The following is a description of a gene set: Human Gene Set: GSE41978_WT_VS_ID2_KO_AND_BIM_KO_KLRG1_LOW_EFFECTOR_CD8_TCELL_UP studied in species Homo sapiens Genes up-regulated in KLRG1 low CD8 T effector cells during infection: wildtype versus ID2 and BCL2L11 knockout. CD8+ T cells play a crucial role in the clearance of intracellular pathogens through the generation of cytotoxic effector cells that eliminate infected cells and long-lived memory cells that provide enhanced protection against reinfection. We have previously shown that the inhibitor of E protein transcription factors, Id2, is necessary for accumulation of effector and memory CD8+ T cells during infection. Here we show that CD8+ T cells lacking Id2 did not generate a robust terminally-differentiated KLRG1hi effector population, but displayed a cell-surface phenotype and cytokine profile consistent with memory precursors, raising the question as to whether loss of Id2 impairs the differentiation and/or survival of effector-memory cells. We found that deletion of Bim rescued Id2-deficient CD8+ cell survival during infection. However, the dramatic reduction in KLRG1hi cells caused by loss of Id2 remained in the absence of Bim, such that Id2/Bim double-deficient cells form an exclusively KLRG1loCD127hi memory precursor population. Thus we describe a role for Id2 in both the survival and differentation of normal CD8+ effector and memory populations. from publication Knell J, Best JA, Lind NA, Yang E, D'Cruz LM, Goldrath AW (PMID 23325888), and this is the list of marker genes: TRIO, NHERF4, SLC14A1, FRYL, IRF1, ZSCAN5B, TUBGCP4, MFAP1, FCER1A, XIAP, HGSNAT, ZNF213, PDCD1, MBD4, GABARAPL1, SEPHS1, GINS4, EEF2K, C1orf159, UBE2C (NCBI Gene Id 11065), SRRD, H2AX, KIF18A, EME1, CXCR3, NT5C, EML5, CUL4B, BCAS3, TEX11, MFSD10, KLHL42, MATN3, CENPM, POPDC3, ACOT9, C19orf53, BIRC5, CREG1, TUSC2, PEX2, PHYH, DLGAP5, ITGA6, EFHD1, GDF5, FBH1, MOS, GMFB, ZNF418, SLC4A5 (NCBI Gene Id 57835), FUT7, RAPSN, FAM53C, CNR2, TRPC4, SYNJ2BP, DGCR6, GAS8, HAUS5, SNRK, CD2BP2, ARL2BP, METRN, IFIT2, LAGE3, SUMF1, TTLL1, NAB1, PAPOLG, CEP15, LEAP2, TIMELESS, NNMT, SIRT1, CEP70, KLHL26, SIT1, SAA1, CPSF7, ZDHHC3, STMN1, DCAKD, HAUS1, TSPYL4, JKAMP, GTF3C5, STIM1, NSG2, KCTD20, OR51B2, NSMCE4A, AAMDC, TMED4, ATP6V1C2, UNK, SNTB1, ELF2, BLOC1S5, ZNF841, ZBTB3, GLCCI1, NYNRIN, NBEA, VWA7, ASF1B, AP1S2, NAA38, PTGS2, NME3, PDLIM5, FAM76A, CLEC4E, AGBL3, DNAJC9, EXOSC9, WEE1, SLC15A2, LAMB1, C8orf33, ADCY4, PIAS1, TCF19, GPR85, IQGAP1, CHRNB3, ASB16, CENPK, NIT1, CD207, RBL1 (RB transcriptional corepressor like 1), CFAP184, GALNT3, RIOX2, MAN2A1, RRAD, NECAB3, CIBAR1, RFWD3, MUTYH, TMEM19, CTNS, MRPS15 (mitochondrial ribosomal protein S15), CD5, SLAMF6, NCF2, TRAPPC12, EMCN, MSH3, PGRMC1, NCOR1, ZNF319, COA6, AVL9, COQ6, BUD13, MMP7, HLA-DRA (NCBI Gene Id 7930), OR5D18, SSNA1, IFT27, CTNNBIP1, CLEC6A, CRIP2, THBS3, CDCA5, NUDT11, ECHS1, ARL6, SLC17A6, DNPH1, GNG10 (G protein subunit gamma 10), TCF7, MED14, RAB23, LRRC2, CAMSAP1, CENPQ, APLP2, MECP2, CD14, ST6GALNAC1, DIO2, TCP11, PRKAG2, SCARB2, DPM2, CCNA2, ELOVL2, RIPPLY3, HEXIM1, HELQ, PRIM1, PHF20L1, NEIL3, IGFBP5, RGS7, STAG1, ABCG1, ADGRL1 (adhesion G protein-coupled receptor L1)